Given this list of marker genes Atg2b (NCBI Gene Id 78864), Ulk1, Atg9a, Atg14, Atg13, Atg16l1, Rb1cc1, Atg2a, Atg16l2, Rab1b, Ulk2, Atg5, Stbd1, Wdr45b, Atg12, Atg9b, Rab7, Wdr45, Wipi1 (WD repeat domain, phosphoinositide interacting 1), Ulk3, Wipi2, here is a description of the gene set: A cellular membrane associated with the phagophore assembly site. Mouse Gene Set: GOCC_PHAGOPHORE_ASSEMBLY_SITE_MEMBRANE species: Mus musculus